The following is a description of a gene set: Human Gene Set: RRCCGTTA_UNKNOWN from publication Xie X, Lu J, Kulbokas EJ, Golub TR, Mootha V, Lindblad-Toh K, Lander ES, Kellis M (PMID 15735639) studied in species Homo sapiens Genes having at least one occurrence of the highly conserved motif M146 RRCCGTTA in the regions spanning 4 kb centered on their transcription starting sites. The motif does not match any known transcription factor binding site. Comprehensive identification of all functional elements encoded in the human genome is a fundamental need in biomedical research. Here, we present a comparative analysis of the human, mouse, rat and dog genomes to create a systematic catalogue of common regulatory motifs in promoters and 3' untranslated regions (3' UTRs). The promoter analysis yields 174 candidate motifs, including most previously known transcription-factor binding sites and 105 new motifs. The 3'-UTR analysis yields 106 motifs likely to be involved in post-transcriptional regulation. Nearly one-half are associated with microRNAs (miRNAs), leading to the discovery of many new miRNA genes and their likely target genes. Our results suggest that previous estimates of the number of human miRNA genes were low, and that miRNAs regulate at least 20% of human genes. The overall results provide a systematic view of gene regulation in the human, which will be refined as additional mammalian genomes become available., and this is the list of marker genes: RBBP8, BANF1, SLC25A14 (NCBI Gene Id 9016), KLHL24, ATF7IP, UBR4, IL1RAPL1, FBXL9P, DIABLO, WEE1, VCP, MAZ, STK16, NRK, MYC, DIS3, CYP1B1, ID1, TFAP2D, EZH2, NFIA, PHTF1, UTP18, AZIN1, GART, AP1M1, DCAKD, CSTF1, MEPCE, UBALD1, CBLL1 (Cbl proto-oncogene like 1), AURKA, NMT1, ZCWPW1, AGBL5, CDC27, SRSF1, SNRPD1, HNRNPC, SUV39H1, LUC7L2, TMEM208, ZMYM4, LRRC36, TUBA1B, KIAA0586, TIMM9, NCAM1, CEP85, TNPO3, ZEB2, ZEB1, RBMXL2, HNRNPR, NECTIN3, HYCC1, ILF3, STC2, TRIM2, VCPIP1, PHF7, UBE2S (NCBI Gene Id 27338), RHBDD3, SON, ILF3-DT, EWSR1, FXR1 (FMR1 autosomal homolog 1), MYH10, PIBF1, VIM, ABHD17B, FNDC3A, BAP1, HRK, NUDCD1, HENMT1, JADE1, EGR3, TAGLN2, C5orf24, SMARCA5, CLDN3, TPI1P2, GLB1L, ADD3, C9orf85, EIF1AD, SF1